The following is a description of a gene set: studied in species Homo sapiens from publication Chen Y, Wang X (PMID 31504780) Genes predicted to be targets of miRBase v22 microRNA hsa-miR-548ad-3p in miRDB v6.0 with MirTarget v4 prediction scores > 80 (high confidence targets). Human Gene Set: MIR548AD_3P, and this is the list of marker genes: CECR2, MAGEH1, CXXC5, SPAST, CBLN1, DNAJC10, MMP16 (NCBI Gene Id 84257), PFDN4, ZCCHC3, ANXA7, BAZ2B, KLF6, MEGF9, BNIP2, SYNCRIP, CITED2, LIN9, ICMT, BIN1, TCF4, ARK2N, YES1, RSKR, ZNF362 (zinc finger protein 362), ODF2L, PRPSAP2